Given this list of marker genes MDH1B, D2HGDH (NCBI Gene Id 728294), ME3, MDH1, ME1, MDH2, LIPF, ME2, FH, here is a description of the gene set: Human Gene Set: GOBP_MALATE_METABOLIC_PROCESS species: Homo sapiens The chemical reactions and pathways involving malate, the anion of hydroxybutanedioic acid, a chiral hydroxydicarboxylic acid. The (+) enantiomer is an important intermediate in metabolism as a component of both the TCA cycle and the glyoxylate cycle.